The following is a description of a gene set: We compared differences in fetal and adult T cells by performing whole genome profiling on sort-purified T cells (naïve CD4+ and Treg cells) from human fetal specimens (18-22 gestational weeks) and adult specimens (age 25-40 years old). Fetal and Adult Naïve CD4+ T cells phenotype: CD3+CD4+CD45RA+CCR7+CD27+, Fetal and Adult CD4+CD25+ Treg phenotype: CD3+CD4+CD25bright from publication Mold JE, Venkatasubrahmanyam S, Burt TD, Michaëlsson J, Rivera JM, Galkina SA, Weinberg K, Stoddart CA, McCune JM (PMID 21164017) Genes down-regulated in comparison of fetal conventional T cells versus adult conventional T cells. Human Gene Set: GSE25087_FETAL_VS_ADULT_TCONV_DN studied in species Homo sapiens, and this is the list of marker genes: DLG3, MAN2B2, NCLN, GPM6B, TXNIP, EBF4, KANK1, DUSP28, ALDH1B1, MICA, ADAMTS17, BAIAP2-DT, STRC, MALAT1, MYLIP, MPHOSPH8, RPL36, UCP2, DHX30, IGSF22, LITAF, ZNF529, NPHP3 (NCBI Gene Id 27031), RNASEL, KLF12, ERO1B, IAH1, GAGE1, ADAM17, DLGAP1-AS1, CREBRF, ZNF204P, CHCHD10, LINC-PINT, SQSTM1, COQ10A, KISS1R, ABHD14A (NCBI Gene Id 25864), TMEM45B, FAM184A, PIK3IP1, ZNF483, ORAI3, NSMCE1, C14orf28, SH3RF3, ZNF211, URI1, MID2, SOX6, SCPEP1, RARB, FOXP1, BMI1, AK5, GATAD1, PATJ, PPARD, PRRT1, EID2B, CENATAC, MAK, FOXO1, PRDM12, TCHP, GAS2, GABPB1-AS1, RGS18, RUFY2, RPS27L, ZFYVE9, PATL2, REM2, ANKRD55, EXOC1, SLC46A1, CHD1-DT (CHD1 divergent transcript), RUSF1, OFCC1, ANKRD49, ZDHHC23, NEXMIF, CTSF, FAM133A, CBY1 (chibby 1, beta catenin antagonist), MEGF6, TNRC6A, MMP28, LYZ, SEPTIN7P2, ZNF662, KIN, SPART, MSL3, PAIP2B, HPSE, TSPO, EPB41L4A-AS1, MICAL1, IL10RA, HLA-DPB1, SLC4A7, NADSYN1, KIF21A, RBM14 (NCBI Gene Id 96086), ACVR2A, SNX1, NHLRC3 (NHL repeat containing 3), ZNF80, MED31, LENG8, WDR73, TRABD2A, PURA, IRS2, LINC00921, TLE4, SNX14, CDC14B, FBXO3, GABBR1, CCDC65, APH1B, NDRG2, ZBTB37, FAM210B (NCBI Gene Id 81895), LINC02035, HELQ, MARCHF10, BEX5, PANK2, VPS35, UPP1, STING1, TSPYL2, RARS2, TRAPPC13, PEX1, TMEM87A, MAP9, TMEM134, CHIC1, BIN2, ZNF540, PHIP, ZBTB7A, CXADR, PFN2, NR3C2, NAALADL1, GPR157, AKR1B1, KLHL10, SRSF1, RASGRP2, NOX5 (NADPH oxidase 5), FBXL16, CWF19L2, FXYD5 (NCBI Gene Id 53827), IMMP2L, TNFAIP8L2, TCP11L2, KLF9, ALMS1, EDAR, IGIP, COA5, PPP1R3E, KMT2E, CEP68, ZNF559, HSD17B11, NEIL2, RAI2, HAX1, PFDN5, GSTA1, VIPR1, TUFT1, TM2D3, DYNLT3, LIG1, PBX3, SLC26A11, CD40, DUSP8, BCL9L, CELF2